Given this list of marker genes ADNP, CDH11, KRAS, SEMA3E, POLR1D, TCOF1, ALX1, LSM11, RIPK4, RNASEH2B, ADAR, FGFR1, DHODH (NCBI Gene Id 1723), EDNRA, SF3B2, TWIST1, POLR1B, TREX1, RPL26, FRAS1, CCNQ, POLR1A, IFIH1, CHD7, SF3B4, RNU7-1, RNASEH2A, FLI1 (NCBI Gene Id 2313), FREM1, RNASEH2C, SAMHD1, ESCO2, TXNL4A, KCTD1, SLC25A24, POLR1C, here is a description of the gene set: Eyelid coloboma species: Homo sapiens A short discontinuity of the margin of the lower or upper eyelid. Human Gene Set: HP_EYELID_COLOBOMA